The following is a description of a gene set: Genes up-regulated in MCF-7 cells (breast cancer) by estradiol (E2). from publication Frasor J, Stossi F, Danes JM, Komm B, Lyttle CR, Katzenellenbogen BS (PMID 14973112) species: Homo sapiens Human Gene Set: FRASOR_RESPONSE_TO_ESTRADIOL_UP Selective estrogen receptor modulators (SERMs) such as tamoxifen are effective in the treatment of many estrogen receptor-positive breast cancers and have also proven to be effective in the prevention of breast cancer in women at high risk for the disease. The comparative abilities of tamoxifen versus raloxifene in breast cancer prevention are currently being compared in the Study of Tamoxifen and Raloxifene trial. To better understand the actions of these compounds in breast cancer, we have examined their effects on the expression of approximately genes, using Affymetrix GeneChip microarrays, with quantitative PCR verification in many cases, categorizing their actions as agonist, antagonist, or partial agonist/antagonist. Analysis of gene stimulation and inhibition by the SERMs trans-hydroxytamoxifen (TOT) and raloxifene (Ral) or ICI 182,780 (ICI) and by estradiol (E2) in estrogen receptor-containing MCF-7 human breast cancer cells revealed that (a) TOT was the most E2-like of the three compounds, (b) all three compounds either partially or fully antagonized the action of E2 on most genes, with the order of antagonist activity being ICI > Ral > TOT, (c) TOT and Ral, but not ICI, displayed partial agonist/partial antagonist activity on a number of E2-regulated genes, (d) several stimulatory cell cycle-related genes were down-regulated exclusively by ICI, (e) the estrogen-like activity of Ral nearly always overlapped with that of TOT, indicating that Ral has little unique agonist activity different from that of TOT, and (f) some genes were specifically up-regulated by TOT but not Ral, ICI, or E2. Hence, gene expression profiling can discern fundamental differences among SERMs and provides insight into the distinct biologies of TOT, Ral, and ICI in breast cancer., and this is the list of marker genes: CA12, AREG, MAPT, EPB41L3, GLRB, RASGRP1, PDZK1, PTGER3, SDC2, NRIP1, CXCL12, CALCR, RET, WWC1, GREB1, PEG10, CCN5, HOXC4, SLC39A6, TOP2A, SLC22A5, OLFML2A, TFF1, FOS (Fos proto-oncogene, AP-1 transcription factor subunit), MPPED2, IGFBP4, RAB31, SIAH2, CYP1B1, ADCY9, PRSS23, MYBL1, EGR3, CDC6, CYP1A1